The following is a description of a gene set: Genes within amplicon 5p15 identified in a copy number alterations study of 191 breast tumor samples. Human Gene Set: NIKOLSKY_BREAST_CANCER_5P15_AMPLICON from publication Nikolsky Y, Sviridov E, Yao J, Dosymbekov D, Ustyansky V, Kaznacheev V, Dezso Z, Mulvey L, Macconaill LE, Winckler W, Serebryiskaya T, Nikolskaya T, Polyak K (PMID 19010930) studied in species Homo sapiens A single cancer cell contains large numbers of genetic alterations that in combination create the malignant phenotype. However, whether amplified and mutated genes form functional and physical interaction networks that could explain the selection for cells with combined alterations is unknown. To investigate this issue, we characterized copy number alterations in 191 breast tumors using dense single nucleotide polymorphism arrays and identified genes with copy number gain organized into 30 amplicons. Amplicons were distributed unequally throughout the genome. Each amplicon had distinct enrichment pattern in pathways, networks, and molecular functions, but genes within individual amplicons did not form coherent functional units. Genes in amplicons included all major tumorigenic pathways and were highly enriched in breast cancer-causative genes. In contrast, genes with somatic mutations in breast cancer were distributed randomly over the genome, did not represent a functionally cohesive gene set, and were relatively less enriched in breast cancer marker genes. Mutated and gained genes did not show statistically significant overlap but were highly synergistic in populating key tumorigenic pathways including transforming growth factor beta, WNT, fibroblast growth factor, and PIP3 signaling. In general, mutated genes were more frequently upstream of gained genes in transcription regulation signaling than vice versa, suggesting that mutated genes are mainly regulators, whereas gained genes are mostly regulated. ESR1 was the major transcription factor regulating amplified but not mutated genes. Our results support the hypothesis that multiple genetic events, including copy number gains and somatic mutations, are necessary for establishing the malignant cell phenotype., and this is the list of marker genes: CCDC127, LPCAT1, EXOC3, NDUFS6, CLPTM1L, ZDHHC11, IRX2, TRIP13, SLC6A19, SLC6A18, NKD2, TERT, SDHA, MRPL36, SLC9A3, LRRC14B, SLC12A7, BRD9, AHRR, TPPP, CEP72, IRX4, SLC6A3, PDCD6, PLEKHG4B, IRX2-DT